The following is a description of a gene set: species: Mus musculus Mouse Gene Set: GOBP_SUBSTRATE_DEPENDENT_CELL_MIGRATION The orderly movement of a cell from one site to another along a substrate such as the extracellular matrix; the migrating cell forms a protrusion that attaches to the substrate., and this is the list of marker genes: Shtn1, Nrp1, Ston1, Fn1, Anks1, Fbln1, Pdgfb, Spag6l, Epb41l5, Fmnl1 (NCBI Gene Id 77175), Robo1, Atp5f1b, Cspg4, Cttn, Ntn1, Stk4, Ptprc, Slit2, Tnfrsf12a, P2ry12, Itga11, Myh10, Nck1, Abl2 (ABL proto-oncogene 2, non-receptor tyrosine kinase), Epha8, Itgb1bp1, Snai2, Itga2, Adam8, Fgfr1